The following is a description of a gene set: studied in species Mus musculus Any process that modulates the frequency, rate, or extent of lymphocyte mediated immunity. Mouse Gene Set: GOBP_REGULATION_OF_LYMPHOCYTE_MEDIATED_IMMUNITY, and this is the list of marker genes: Il20rb, Clcf1, Klrc1, Zp3, Trpm4, Pik3r6, Il12b, Hmgb1, Il4i1, Slc22a13, Ap1g1, Lilrb4a, Nsd2, Serpinb9h, H2-M1, Il4, H2-M11, Cd160, Slamf1, H2-M2, Dennd1b, Nectin4, Sh2d1b1, Dusp22, Pnp, Vsir, Klrb1a, H2-Q7, Igf2, Nectin2, H2-T23, Il1b, H2-M10.6, H2-Q2, Il2, Klrc3 (NCBI Gene Id 58179), Clec12b, Stat6, Cr1l, Rsad2, Cd1d1, Il18rap, Raet1d, Mlh1, Mr1, Trp53bp1, Nod2, P2rx7, Tnfsf4, Havcr2, Ighg1, Prkcz, Muc4, Arrb2 (arrestin, beta 2), Ighg2b, Il23a, Cd80, Bcl6, H2-T22, Ceacam1, Lamp1 (lysosomal-associated membrane protein 1), Tgfb1, H2-K1, Cd81, Fbxo38, Lag3, Crtam, Klhl22, Shld2, Slamf6, H2-Ea, Cd226, Tnf, Klrb1c, Klri2, Hpx, H2-M10.1, Fcgr2b (NCBI Gene Id 98391), Serpinb9d, Ptpn6, Klrb1, Klrb1f, H60c, Mir181b-2, Ahr, Tfrc, Klri1, Lilrb4b, Cadm1, Ager, Trem2, Traf2, Ywhag, Smad7, Il1r1, H2-M3, Shld1, Map3k7, Tbx21, H2-T5, Aplf, Serpinb9e, H2-Q4, Atad5, B2m, Il18, Nlrp3, H60b, Clec4g, Pagr1a, Mir181b-1, Rasgrp4, Klre1, Hmces, Malt1, Raet1e, Cd55, Parp3, H2-M10.4, Btk, H2-T13, H2-T24, Ccr2, Ccl20, Il18r1, Cyrib, Stat5b, Prkaa1, H2-M10.2, Fcgr3, Ptprc, Exosc6, Stat5a (NCBI Gene Id 20850), Grb2, Foxp3, Tnfrsf1b, Gimap5, H2-T3, Gfer, Pms2, Nckap1l, Tap1, H2-M10.5, Mill1, Clec2d, Mad2l2, Ulbp1, Il21, Rif1, Klrb1b, Fut7, Fcer2a, Lgals9, Zbtb1, Tap2, Serpinb9b, Paxip1, C4bp, Kmt5b, Gata3, Arg1, H2-Q6, Rasgrp1, H2-Q1, Cd24a, Cd55b, Sh2d1a, Serpinb9f, 2410137M14Rik, Il12a, Cd28, H2-M10.3, Hfe, Cd1d2, Msh2, Stx7, Shld3, Xcl1, Spn, Il7r, Vav1, Fcer1a, Serpinb9c, Il6, Cr2, Serpinb9, H2-Q10, Exosc3, Supt6, Klrc2, Kmt5c, Clnk, Il27ra, Sash3, C3, Pvr, Ppp3cb, Cd274 (NCBI Gene Id 60533), Sh2d1b2, Was, Ripk3, Cd40, Fcgr1, Klrd1, 6030468B19Rik, Arid5a, Ndfip1, H2-M5, Azgp1, Lta, Fzd5, Ifnb1, Hspa8, Klrk1, Foxj1, Tnfsf13, Lep, Zp3r, Fadd, Traf6, Ifng, Inpp5d, Pdcd1, Susd4, Calhm6, Slc15a4, H2-D1, H2-M9, Serpinb9g, Dpp4, Ufl1, Cd46, Fcer1g, Cd96, Gimap3, BC037156, Crk, Hspd1, Ncr3-ps, H2-T15